The following is a description of a gene set: studied in species Mus musculus Mouse Gene Set: GOBP_CEREBRAL_CORTEX_NEURON_DIFFERENTIATION The process in which a relatively unspecialized cell acquires specialized features of a neuron residing in the cerebral cortex., and this is the list of marker genes: Cntn2, Elavl4, Nr2e1, Lhx6, Eomes, Rac3, Emx1, Dlx1, Rac1 (Rac family small GTPase 1), Nkx2-1, Hprt1 (hypoxanthine phosphoribosyltransferase 1), Id4 (NCBI Gene Id 15904), Psen1, Hes1, Neurog2, Zfp335, Gdpd5, Lypd6, D16Ertd472e, Chd5, Sin3a, Kcnq2, Tox, Ascl1, Arx, Drd1, Fezf2, Pafah1b1, Pex5, Dlx2, Drd2, Ophn1